Given this list of marker genes Upp1, Upb1, Nt5c1a, Tymp, Nt5c, Dpyd, here is a description of the gene set: This event has been computationally inferred from an event that has been demonstrated in another species.<p>The inference is based on the homology mapping from PANTHER. Briefly, reactions for which all involved PhysicalEntities (in input, output and catalyst) have a mapped orthologue/paralogue (for complexes at least 75% of components must have a mapping) are inferred to the other species. species: Mus musculus Reactome Pathway: Pyrimidine catabolism electronically inferred by orthology from the curated human pathway part of: Nucleotide catabolism